Given this list of marker genes ANAPC4, XRCC5, TRAPPC8, CCT8L2, PRKAG2, CCT5, BLOC1S6, POLD2, NCBP2, RNF19A, RBCK1, HSPB1, FBXO31, PRKACB, DDB1, PIGV, BRCA2, RACGAP1, EIF4E, LRRC75A, AMBRA1, PSMA2, TRAPPC12, NAA15, AGO2, POLR2A, PRKAA1, PAF1, PAAF1, PRAMEF17, TOPORS, CARD11, ZBTB8OS, SPAG1, RNASEH2B, AMFR, UXT, FBXL15, MAP3K7, LIG4, MMS19, PTGES3, POP1, PSMB11, DCAF4L2, KCTD13, RNF31, RNF2, KLHL41, ACTB, LEO1, TAF11L6, TRAPPC1, WDR83OS, PPP3CC, TBP, BCL10, SPSB3, PRKY, KBTBD8, KLHL12, AXIN2, TRAPPC13, BCAS4, KLHL1, NAA20, RMC1, ERCC3, SPSB1, MED1, CAND1, RASGRP3, DGCR8, LARS1, DAW1, UBR2, BORCS7, PAXX, PSMB6, PSMD9, TAF11L3, POLR3E, ZFP36, PRKAR1A, GSK3A, POLR1A, POLR1B, POTEJ, PSMB3, POLA2, CHRAC1, FBXL6, NIN, EPC1, REV3L, KLHL35, ENC1, SOCS7, RNF7, YBX1, ENY2, TOB1, RNF20, DZIP1, AIMP1, KANSL1L (KAT8 regulatory NSL complex subunit 1 like), CNOT6, PPP5C, ANAPC11, TAF13, SHARPIN, KLHDC3, FBXL2, RNF19B, HCFC1, CAMK2A, RNASEH2C, KAT6B, SKIC8, FAM98A, LAMTOR2, UBQLN1, KLHL8, TADA2B, PSME4, ACTL6B, KLHDC10, MED17, DCAF16, AMN1, KLHL18, AGO4, TSN, NAA16, EIF4E2, FBXO32, ELP6, SYVN1, BAG3, SESN3 (sestrin 3), KLHL2, RAD51, PHC1, MYZAP, CBX7, FBXO48, PRR5, DHX9, UBE2E1, TRAF2 (TNF receptor associated factor 2), PRKAA2, CCZ1B, EIF4A2, SNAP25, POTEKP, PSMD10, CDK7, JADE3, KCTD2, POLR2J, KLHL11, DTNBP1, CEP170, TAF6L, ECPAS, CCT7, MUS81, CDC27, CNOT9, PRAMEF26, BRPF3, LMO7, KLHL38, DCAF12L2, BMAL1, SLX4, PEX2, MSL2, MRGBP (NCBI Gene Id 55257), KLHL23, FBXL14, KCTD17, ZSWIM8 (zinc finger SWIM-type containing 8), PSMF1, DCUN1D1, POLE4, FBXW4, AHR, TAF4B, EPC2, ASB1, POTEE, ATP23, KAT5, ELP1, GTF2H1, NAA25, RBX1, KLHL15, ACTL6A, TAF10, SDF2L1, PIH1D2, CCDC120, CLP1, POLR2K (RNA polymerase II, I and III subunit K), MED11, PRAMEF4, CCNH, PCGF1, UBE2N, SPSB4, TSEN54, IKBKG, CNOT1, VPS72, GTF2H2, KLHL28, EIF2B5, FBXL3 (NCBI Gene Id 26224), CUL2, LARP1, EME2, PSMA6, PSMB2, PDCD6, RPAP1, BLOC1S2, CARD9, PRR5L, POLR1C, EIF4E3, DDB2, TAF7L, DNA2, RMND5B, MAD2L2, POLR1H, PRAMEF12 (PRAME family member 12), EME1, CUL1, DYRK2, CIAO3, POLE3, KLHL21, POLR3G, TXNL1, DPM2, ARIH1, ELP5, RAD18, POLR3B, NCBP3, KAT7, EIF4G2, ZYG11B, OTUD6B, HPS4, STUB1, ANAPC10, DACT1, DCUN1D4, KLHL3, PRKN, GTF2H4, POTEF, DCTN1, TAF11L13 (NCBI Gene Id 112488747, TATA-box binding protein associated factor 11 like 13), TRAPPC3 (trafficking protein particle complex subunit 3), TSC1, DCAF12, MARCHF6, C9orf72, KLHL17, SKP1, ZSWIM4, TSEN2, PSMB5, PRKAR2B, SMCR8, ERCC2, FBXO27, SUPT3H, ZZZ3 (zinc finger ZZ-type containing 3), ABAT, CCT2, RNF40, JADE2, POLR1D, FBXO8, KAT6A, BMAL2, ACTBL2, SCLT1 (sodium channel and clathrin linker 1), PRKRA, CNOT4, GID4, FBXL16, RNF144A, PSMB7, DCUN1D2, MEAF6, CAMK2D, NFKBIA, RNF168, FBF1, AKAP14, MED21, EEF1E1, TAF1, CBX2, TAF11L12, KLHDC2, COMMD1, UBE2C, ANAPC5, PRICKLE1, TRAPPC6B (trafficking protein particle complex subunit 6B), CBLL1, UBR3, POLR2I, PRORP, CCT6A, DCAF4L1, POLR2F, DCAF15, TAF11L14, SPOPL, ELMO1, PSMG2, PSMD4, UBE3C, ING3, POLR3D, MSL3, PSMC6, KLHL24, RAD23B, DET1, TRAF3, CUL5, TAF11L10, PPP3CB, MED27, FBXO2, TRMT10C, FBXL21P, XRCC6, PSMA1, ZFAND2B, BUB1B (BUB1 mitotic checkpoint serine/threonine kinase B), TBPL1, PFDN2, CDC73, RPP25L, UBAC1, URI1, PHC2, UBE2S, WDR77, CEP89, FBXL5, CDC37, MAPKAP1, BCOR, PDE3B (NCBI Gene Id 5140), KEAP1, TRRAP, RPP21, MAT2A, ANKIB1, BRAP, TAF11, FBH1, DCAF1, TSEN34, SNAP47, ASB9, PSMC3 (NCBI Gene Id 96121), PGGT1B, DCAF8, FBXW5, HNRNPU, DNAAF2, CAMK1G, FAM8A1, TAF11L4, OGT, ASB11, TAF2, RTRAF, FBXO39, DDA1, ATXN7, TRAF7, RUVBL2, PSMG1, AGO3, MAEA, DTL, ANAPC13, DOCK1, RPP14, RNF144B, CKS2, MSL1, IGF2BP1, PHF20L1, CBX6, MIB2, GTF2F1, ING4, FEM1A, PRAMEF13, RPPH1, BRCC3, PRAMEF14, TCP1, BLOC1S3, MAT1A, ANAPC2, GAN (gigaxonin), IVNS1ABP, CDKN1B, HSPA8, ARMC8, TAF6, CCT3, TADA3, APC2, PHF20, TAF4, PSMA5, CARD10, LAS1L, KLHL30, PSME2, KAT2B, ANAPC16, DCAF10, ADRM1, C2orf49, FBXW8, PSMA4, PSMB1, BTRC, WWP1, BRD1, PSMC4, FBXL19, PSMD6, LAMTOR1, RAD23A, KCTD5, PSME3, FZR1, ZSWIM5, PSMB8, KLHL42, UBE2A, KLHL5, TERT, CEP83, DCUN1D5, TRPC4AP, ARMC5, PRAMEF15, KBTBD2, KBTBD6, POLRMT, MED6, KLHL29 (kelch like family member 29), KLHL13 (NCBI Gene Id 90293), RIC1, CNOT7, PCMTD1, WWP2, PRKAB1, OS9, POLR2M, CDC20B, EIF4G1, ANAPC15, FNTA, HSP90AB1, SUPT20H, EIF4G3, USP33, CSNK2B, PFDN6, DCAF5, ELOB, PRKAB2, SEL1L, UBE2V2, MALT1, KLHL6, ACTG1 (NCBI Gene Id 71), PRAMEF33, PRAMEF6, FBXL12, PI4K2A, CAMK2G, WDR5, WDTC1, WDR26, PPP3R1, DCAF8L1, KLHL20, KLHL9, BORCS5, PRIMPOL, UBE2U, APPBP2, EP400, RCHY1, YEATS2, NFKB1, YPEL5, FBXL4, RPP40, CSNK2A3, TCEA1, CSNK1A1, KAT14, FBXW11, MKLN1, PRAMEF2, DROSHA, AIP, OTULIN, BLOC1S1, ELOC, UBXN8, YEATS4, DDX1 (DEAD-box helicase 1), GLMN, UBE3D, EIF2B4, FBXO3, PSMA7, ECT2, IDE, TENT2, DMAC2, GTF2A1L, CIAO1, EIF4E1B, FAM98B, PRAMEF9, PCGF3, FBXO46, TRAPPC2, MORF4L2, MTOR, UBE2J1, DARS1, CNOT3, POLR2J3, ARNT2, KLHL10, DCAF11, PPP3R2, UBE2V1, DEPDC5, EIF2B2, ELP4, TAF11L9, NCCRP1, MED30, SNAPIN, DCAF17, FBXO15, MCRS1 (microspherule protein 1), SESN2, RNF8, PRAMEF7, PSMB10, PCGF2, PRAMEF25, LZTR1, PRAMEF11, PSMD13, CDC20, CCT6B, ARIH2, KNDC1, CRBN, POP5, TAF11L2, FBXO6, TARBP2, PRAMEF1, TRAPPC11, RGP1, PRIM1, GATB, UBE2L3, TRAPPC2L, PRAMEF22, PRKACA, RTF1, BORCS8, CNOT10, CCT8, PRKAG3, GTF2E1, NAA10, BLOC1S5, IPP, ASB2, ODF2, ABTB1, NHEJ1, KBTBD12, POLR3H, POLR1F (NCBI Gene Id 378048), CSDE1, CIAO2A, CBX4, EIF2B1, STRADA, CUL7, PRAME, TADA2A, BMI1 (NCBI Gene Id 648), UBR1, AHRR, SYNCRIP, LAMTOR4, CDC23, BAG2, PEF1, KIF23, BRCA1, NCBP1, CREBBP, TRAPPC2B, SAMD7, TAF5, PSMA8, RANBP9, BCL3, PSMD1, PRAMEF10, UBE2J2, POLA1, ZNF326, SGF29, USP14, POLR1E, SIAH1, PSME1, RPP30, GPR37, KAT8, POLE, UBE4B, POLR3K, DCAF6, EIF4H, TAF3, MSL3B, MED10, PIGM, KCTD10, CNOT2, ARNT, PSMD3, NAA50, KLHL40, SOCS2, SPOP, PRKDC, STX12, DCAF12L1, NCBP2L, CTR9, MED8, POLR2B, LAMTOR3, TAF9B, PHC3, PRAMEF19, AKT1S1, TAF7, SUPT7L, POLD4, BRPF1 (bromodomain and PHD finger containing 1), NAA11, DCUN1D3, TMEM183A, POLR2G, POP4, POLR2J2, RANBP10, PSMD5, RICTOR (RPTOR independent companion of MTOR complex 2), MBIP, SEM1, BABAM2 (NCBI Gene Id 9577), GATC, KXD1, KLHL25, RMND5A, FBXO7, RNF11, FBXO10, ZER1, ELP2, NAA38, GTF2H2C, CDC16, ASB12, APC, CCT4, QRSL1, TRAPPC10, SDF2, POLG, FBXO44, RNASEH2A, DNAJB2, HERPUD1, COP1, RARS1, POLE2, GSK3B, MED7, TTI1, ELP3 (NCBI Gene Id 55140), GTF2E2, CTNNBIP1, FBXO21, HPS5, PSMD7, CEP128, CBX8, FBXO11 (NCBI Gene Id 80204), MAVS, KLHL22, SUPT20HL2, GTF2A1, MON1A, CUL4A, SPSB2, POLR1G, NAA35, CENPF, ANAPC7, STK11, POLR2C, NEDD4, POLR2H, POLR3C (RNA polymerase III subunit C), PSMC5, POLR2D, FBXW7, POLR3A, CNOT11, BLOC1S4, TMEM183BP, KANSL1, POLR3GL, RNF14, SUPT20HL1, TAF12, PSMC1, FBXO4, NAA30, AKAP4, CCIN, KARS1, UBE4A, ING5, HPS3, MGRN1, TUFT1, FBXO17, FBXO45, UCHL5, DPM1, DMAP1, PRKAR1B, GTF2B, DNAJC9, GID8, GTF2H2C_2, KANSL2, DCAF4, RING1, CCT8L1P, ZFAND2A, SUGT1, MED12, PRAMEF20, CTNNB1, WDR18, CDC26, FEM1C, GTF2H5, AIMP2, UBQLN4, HSF1, KIF2A, USP22, TSNAX, PSMD8, ATF2, GTF2H3, CUL9, KANSL3, ERCC8, FEM1B, SLC38A9, SF3B5, PRAMEF5, CNOT6L, POTEI, BARD1, CEP164, HPS6, TAF11L8, PSMD12, ACTL8, POLR2L, RAP1A, DPM3, DCAF13, EIF4B, FBXL7, HSD17B10, LAMTOR5, MED31, WDR41, CSNK2A2, POMT1, ATXN7L3, FBXO25, CTU1, ITPR1, FBXO24, UBE3A, TRAPPC6A, GTF2A2, MNAT1, EPRS1, RPAP3, TRAPPC9, CCDC47, DNAJB11, AGO1, HPS1, POLR2E, PSMD14, POLG2, MLST8, ERN1, CCDC61, PSMC2 (proteasome 26S subunit, ATPase 2), XRCC4, MBTD1, FBXO9, CUL3 (NCBI Gene Id 8452), POLD3, PRKAR2A, HSPB8, TAF9, CRCP, PSMB4, PDRG1, PSMA3, CAMK2B, PRAMEF18, TRIM21, MORF4L1, ZNFX1, TAF5L, QARS1, ANKRD9, TRAPPC14, BRD8, CCDC68, SF3B3, KLHL4, EIF2B3, TRAPPC5, ASB4, RAG1, VCP, BORCS6, DR1, TADA1, MON1B, KBTBD7, JADE1, STIP1, EIF4A1, PRKAG1, NFKB2, KLHDC1, EIF4EBP3, USP47, KBTBD3, CCNF, ZYG11A, ZSWIM6, WASHC4, POLR3F, ANAPC1, CUL4B, KLHL7, SAMD11, SMURF2, RTCB, CSNK2A1 (NCBI Gene Id 1457), PATL1, CKS1B, EP300, PRAMEF8, CCAR2, TRAPPC3L, DCAF8L2, TRAPPC4, GTF2F2, MCM3, CNOT8, RUVBL1, TNKS1BP1, TAF11L7, FBXO42, UBE2B, CACYBP, PRIM2, FAM98C, POLD1, CPEB3, CNTRL, IARS1, TNFAIP1, RNF217, CIAO2B, KAT2A, RPP25, PSMB9, PRKX, PSMD2, TAF8, DCAF7, TAF1L, FBXO38, DCLRE1C, SKP2, TAF11L11, PSMD11, PCGF5, PRKACG, RPP38, AXIN1, MAT2B, POP7, CCZ1, MARS1, PPP3CA, FBXL17, PCGF6, FBXL20, PRAMEF27, RPTOR, FBXL13, MEGF8, DICER1, here is a description of the gene set: A protein-containing complex located intracellularly. studied in species Homo sapiens Human Gene Set: GOCC_INTRACELLULAR_PROTEIN_CONTAINING_COMPLEX